Given this list of marker genes ABCD1, MT-ATP6, ZFYVE26, DARS2, ANO10, ATP13A2, PI4KA, KIF1A, KIF5A, CRYAB, PODXL, LDB3, SPAST, SYNJ1, VAMP1, DNAJC6, here is a description of the gene set: species: Homo sapiens Human Gene Set: HP_LEG_MUSCLE_STIFFNESS Leg muscle stiffness